The following is a description of a gene set: studied in species Mus musculus A cell-cell adherens junction which forms a continuous belt near the apex of epithelial cells. Mouse Gene Set: GOCC_ZONULA_ADHERENS, and this is the list of marker genes: Camsap3 (calmodulin regulated spectrin-associated protein family, member 3), Ctnnd1, Ctnna1, Kifc3, Plekha7, Vcl, Nectin2